The following is a description of a gene set: Corneal guttata Human Gene Set: HP_CORNEAL_GUTTATA studied in species Homo sapiens Corneal guttata are droplet-like accumulations of non-banded collagen on the posterior surface of Descemet's membrane. The presence of focal thickenings of Descemet's membrane histologically named guttae. Cornea guttata can be easily diagnosed in vivo and ex vivo by means of specular microscopy as it gives dark areas where no endothelial cells are visible., and this is the list of marker genes: SLC4A11, TCF4, KCNJ13, ZEB1, AGBL1 (NCBI Gene Id 728206), COL8A2